The following is a description of a gene set: Mouse Gene Set: CBX6_TARGET_GENES from publication Yevshin I, Sharipov R, Kolmykov S, Kondrakhin Y, Kolpakov F (PMID 30445619) studied in species Mus musculus Genes containing one or more binding sites for (Cbx6) in their promoter regions (TSS -1000,+100 bp) as identified by GTRD version 20.06 ChIP-seq harmonization., and this is the list of marker genes: Gfra2, Gm1401, Prdm16, Stx8, Tmem38a, 1700039I01Rik, Med13, Vwa2, Atosb, Gm25268, Myb, Prox1os, Trp53inp1, Dclre1c, Tlcd2, mt-Tl1, Clptm1l, Phc1, Palld, Lrrc7, A830082K12Rik, Shox2, H2az2, Polr1h, Idh1, Trib1, Secisbp2l, Foxl2os, Gpat3, Prok2, Klhl5, Hoxd3, Lingo1, Dsp, Wdtc1, Mus81, Exoc4, Tmem178b, Rreb1, Tbr1, Prodh, Nkx2-2, Apba2, Prr16, Gfra4, Kdm4c (NCBI Gene Id 76804), 4930455B14Rik, Sema4c, Usp35, Cxxc4 (CXXC finger 4), Tenm2, Fibcd1, D430040D24Rik (NCBI Gene Id 319678), Mynn, Kctd21, Kmt2a, Zfp536, Lig4, Ap2a1, Eya4, Srsf11, Vwc2, Igf1, Fendrr, Gm20467, Robo2, Hoxd11, Ccr9, Zic1, Runx3, Foxl2, Mrps31, Trp53inp2, 5330413P13Rik, Hand1, Dll1, Slc35d3, Pitx2, Natd1, Cwc25, Snx12, Fxyd7, Mdga2, Gm12446, Six3, Meis1, Lrrc40, Fam111a, Ndufs7, C530025M09Rik, Gar1, Scrt1, Wt1os, Hivep2, Zfyve1, Slc39a3, Rsrc1, Mir6973b, Mob3c, Kcnc1, Sntg1, Mfsd2a, Cacnb2, C330002G04Rik, Ripply3, Gm16096, Xpnpep1, Bcl11b, Msx2, Nr2f1, mt-Nd1, Zfp398, Mir22hg, Cfap52, Caap1, Sdk2, Ypel5, Foxe1, Pde4d, Ly6h, Meis2, Adra1d, Cfap20dc (NCBI Gene Id 78904), Hoxaas3, 4930580E04Rik, Rnf43, Pikfyve, Ripply2, Keap1, Nutf2, Hoxb2, mt-Rnr2 (NCBI Gene Id 17725), Gm10369, Vgll4, 2610005L07Rik, 9030622O22Rik, Ado, Ptk2 (NCBI Gene Id 14083), Nop58, Gata2, Gm5067, Prox1, Sart3, Erbb4, Ctdspl, Plekhb1, Speg (SPEG complex locus), Hmox1, Usp32, Cd63, Whrn (whirlin), Cdc20b, Ak1, Pipox, B230323A14Rik, Kcnk6, Wt1, Zswim8, Pym1, Isl2, Prdm16os, Lmbr1l, Ndufb2, Fli1, 9130410C08Rik, Cic, Nsg1, 4933421A08Rik (RIKEN cDNA 4933421A08 gene), Hoxa9, Zfp516, E130018O15Rik, Slc16a10, Iscu, 4930426L09Rik, Trim2, Esam, Mmp25, Col27a1, Tdh, Kcnk12, Nkx2-3, 1600012H06Rik, Jtb, E230013L22Rik, Hif1a, Bmf, Trp73, mt-Tv, Smim7, Igf2os, Foxp2, Trip4, Wdr7, Prdm4, Polr1has, Atp10d, Tsr3, A230083N12Rik